Given this list of marker genes Ap1ar, Jmy, Dnai3, Coro1b (NCBI Gene Id 23789), Gmfg, Avil, Wasf3, Wasf1, Gmfb, Pick1, Wmp (WAVE homology in membrane protrusions), Snx9, Iqgap2, Whamm, Nckipsd, Cttn, Wasf2, here is a description of the gene set: studied in species Mus musculus Mouse Gene Set: GOMF_ARP2_3_COMPLEX_BINDING Binding to an Arp2/3 complex, a protein complex that contains two actin-related proteins, Arp2 and Arp3, and five novel proteins (ARPC1-5).